Given this list of marker genes Bloc1s6, Kitl, Bloc1s5 (biogenesis of lysosomal organelles complex-1, subunit 5, muted), Gna11, Gnaq, Adamts9 (NCBI Gene Id 69070), Bcl2, Zeb2, Adamts20, here is a description of the gene set: Any process that modulates the frequency, rate or extent of pigmented cell differentiation. Mouse Gene Set: GOBP_REGULATION_OF_PIGMENT_CELL_DIFFERENTIATION studied in species Mus musculus